The following is a description of a gene set: While BRAF-specific inhibitors inhibit MAPK/ERK activation in the presence of the BRAF V600E mutant, paradoxical activation of ERK signaling has been observed after treatment of cells with inhibitor in the presence of WT BRAF. This paradoxical ERK activation is also seen in cells expressing kinase-dead or impaired versions of BRAF such as D594V, which occur with low frequency in some cancers. Unlike BRAF V600E, which occurs exclusively of activating RAS mutations, kinase-impaired versions of BRAF are coincident with RAS mutations in human cancers, and indeed, paradoxical activation of ERK signaling in the presence of inactive BRAF is enhanced in the presence of oncogenic RAS. Although the details remain to be worked out, paradoxical ERK activation in the presence of inactive BRAF appears to rely on enhanced dimerization with and transactivation of CRAF. RAF inhibitors can promote association of RAF-RAS interaction and enhanced RAF dimerization through disruption of intramolecular interactions between the kinase domain and its N-terminal regulatory region. Moreover, specific BRAF inhibitors can only occupy one protomer within the transcactivated BRAF dimer due to negative co-operativity leading to paradoxical ERK activation.. Reactome Pathway: Paradoxical activation of RAF signaling by kinase inactive BRAF part of: Oncogenic MAPK signaling species: Homo sapiens, and this is the list of marker genes: PEBP1 (phosphatidylethanolamine binding protein 1), FN1, ITGB3, KRAS, MAP2K1, ACTB, CNKSR2, MAP3K11, CNKSR1, SRC, YWHAB, CAMK2A, JAK2, ARAF, CAMK2G, RAP1B, RAP1A, CAMK2D, PHB1, ARRB1, MAP2K2, BRAF, BRAP, FGA, CALM1, KSR1, FGG, IQGAP1, CSK, FGB, VWF, NRAS, ARRB2, RAF1, ITGA2B (NCBI Gene Id 3674), HRAS, KSR2, VCL, MAPK1, MAPK3, APBB1IP, ACTG1, MARK3, CAMK2B, TLN1